Given this list of marker genes Zcchc14, Frat2, Akt3, Phf8, Batf3, Rcor1, Uhrf1, Lrrc73, Fut9, Ccdc47, Hrh1 (histamine receptor H1), Edc3, Cenpv, Amot, Dpp10, Trim37 (NCBI Gene Id 72353), Rbm15, Arhgef12, Zfp706, Kdm3a, Tagln, Pogk (pogo transposable element with KRAB domain), Slc6a1 (solute carrier family 6 (neurotransmitter transporter, GABA), member 1), Ube2k, Trib2, Prpf38a, H3f3b, Ubn1, Ctsc, Khnyn, Pik3cd, Fbxl19, Lrch1, Ehd1, Cpeb1, Max, Trub1 (TruB pseudouridine (psi) synthase family member 1), Kcnh1, Micos13, Lrrc1, Fbrs (fibrosin), Creb1, Cyrib, Grk1, Chd9, Gatm, Cyth3, Lonrf2, Wasf1, Vasp, Msl2, Ogn, Hoxa4, Pdss1, Tnrc6b, Ttyh3, Mthfr, Kat6a, Mat2a, Fgf23, Flvcr2, Ppp1r15b, 4933402D24Rik, Arrb1, Rsbn1, Unk, Plcxd3, Kcnk10, Klf6, Mecp2 (methyl CpG binding protein 2), Ercc8, Npnt, Btg1, Fam168b, Vezf1, Grm5, Carmil1, Wdr82, Lin7c (lin-7 homolog C, crumbs cell polarity complex component), Trp53inp1, Rab5b, Cav3, Naa20, Meis2, Ddit4, Brwd3, Sirt1, Cacul1 (CDK2 associated, cullin domain 1), Ikzf4, Pdik1l (NCBI Gene Id 230809), Elovl6 (NCBI Gene Id 97061), Cebpd, Tub, Bcl9, Ankrd13a, Esr1, Trim66, Snx30, Styx, 4930523C07Rik, Homer1, Net1, Tbc1d20, Clic4, Stag2, Cdh4, here is a description of the gene set: Genes predicted to be targets of miRBase v22 microRNA mmu_miR_22_3p in miRDB v6.0 with MirTarget v4 prediction scores > 80 (high confidence targets). from publication Chen Y, Wang X (PMID 31504780) Mouse Gene Set: MIR_22_3P studied in species Mus musculus